The following is a description of a gene set: Any process that stops, prevents, or reduces the frequency, rate or extent of ossification, the formation of bone or of a bony substance or the conversion of fibrous tissue or of cartilage into bone or a bony substance. species: Homo sapiens Human Gene Set: GOBP_NEGATIVE_REGULATION_OF_OSSIFICATION, and this is the list of marker genes: GATA1, MDK, BCOR, TGFB1, LRP4, RFLNB, BMP3, SMAD3, LTBP3, PTK2B, RBPJ, MEF2C (NCBI Gene Id 4208), GREM1, ACVR1B, SMAD7, SRGN, HIF1A, CCR1, ACVR2B, KREMEN1, RFLNA, DKK1, TMEM53, PTH, SOX9, CHSY1, ECM1, MIR208A, CALCR, AHSG, BCL2, SMAD6, GFRA4, NOTCH1, SOST, SFRP1, SMAD2, ENPP1, KREMEN2, STATH, FGF23, GDF10, CCL3, TRPM4